The following is a description of a gene set: Any process that activates or increases the frequency, rate or extent of cell differentiation. species: Homo sapiens Human Gene Set: GOBP_POSITIVE_REGULATION_OF_CELL_DIFFERENTIATION, and this is the list of marker genes: LCK, TNFSF14, AGTR1, CLDN5, CLCN2, LEF1, FGF20, NPTN, MCUB, HLA-DRB1, KRAS, TCF15, LAMB2, JUNB, MYOG, JAG1, CHODL, KLF10, NRCAM, JUND, CXCL9, SKIL, MIR21, TRPM4, IL6ST, ACTB, CD74, NPPC, XKR8, TACSTD2, ARID1A, LRRC8A, BMPR2, SMAD4, MDK, ACIN1, WWTR1, HES1, SMARCD1, CD34, RANBP3L, DBN1, RHEB, EP300, TLR9, DAB1, CSF2, CSF3, CEBPD, RASGRP1, FADD, CYP27B1, PCID2, FOXN1, EVI2B (ecotropic viral integration site 2B), RARA, TRPV2, CD101, CCN1, PBRM1 (NCBI Gene Id 55292), LGALS3, STAT5A, INS, PLA2G2A, FXR2, NKX2-5, PARP6, ZHX3, ETV2, TGFBR2, ASB4, ANKRD27, GDI1, BMAL1, RAP1A, PARP1, ACVR2A, LRP3, IL13, VSTM2A, TESPA1 (NCBI Gene Id 9840), PCP4, BRINP2 (NCBI Gene Id 57795), ARID2, ACTN3, FRZB, ZAP70, MAMSTR, OLFM2, NIN, MYOD1, GOLGA4, ROBO2, FEZF1, CTNNB1, WNT2, RPS6KA3, BRD1, NR6A1 (nuclear receptor subfamily 6 group A member 1), IL2, NGF, NOCT, RPTOR, EPO, SHH, NRDC, SHTN1, LIMK1, MIR142, NEUROG1, PRMT5, PRMT3, TARBP2, FZD3, BTC, IL21, QKI, DISC1, HLA-DRA, CUL7, NME2, SERPINE2, CDH4, TGFB1, SMYD1, PCK1, MYOCD (myocardin), CR1 (complement C3b/C4b receptor 1 (Knops blood group)), TFE3, MIR27A, GHR, ISL1, MALT1, PAX8, GDPD2, PNP, SLITRK1, MIR20A, RB1, RAB21, CREBL2 (cAMP responsive element binding protein like 2), IL10, CAPRIN2, RUNX3, ITGB1, EEIG1, FGF18, STAU2, VWC2L, ADCY10, MAP1B, PRKCH, CMKLR1, MIR17 (NCBI Gene Id 406952), ACTL6B, SOX6, IL5, PAX2, MPL, SLC7A5, HOXA5, GATA2, DSCAM, SMARCD2, TP63, IL15, BRINP1, IPO7, SDCBP, MACROH2A2, ADAM7, DLX2, ADM, ALX1, NKAP, ZNF219, F11R, TBX1, SPAG9, TCF7L2, NFKBIZ, GLI2, MIR150 (NCBI Gene Id 406942), DKK1, BCL6, SOCS2, PIAS1, MIR204 (NCBI Gene Id 406987), PTCH2, GATA3, PWP1, CYLD, DDR2, PPP1R13L, BMP6, BCL2, SRF, HOXD3, ZFP36L1, SIRT6, SLIT2, SOX13, PPP1CC, MICOS10-NBL1, SOX10, KITLG, CDKL3, MIR145, ROBO1, CCN3, PTK2, GFAP, INHBA, ADNP, LPAR3, CSRP3, EGR2 (NCBI Gene Id 1959), SP7, LMOD3, LTF, APOB, BOC, TNF, TCF3, BMP10, TWIST1, EDN1, LIN28A, ITPKA, TRIB1, SMARCC1, ETV4, ABCB10, MUSTN1, RHOA, FOXJ1, SOX17, PDPN, ZNF703, RIN2, PHF10, SIX1, MIR221, MESP1, ZEB2, SOX9, ASCL1, MIR99B (microRNA 99b), FN1, CDON, RNF112, SOCS5, MIR137, ZNF335, TP73, RUFY3, AMIGO1, NRP1, ZFHX3, ADAMTS20, MDM2, SPRR5, SH3GL3, FAM210B, HAX1, ADD1, NTRK2, HAP1, KHDC3L, WDR62, GDF5, MAP2K1, HNRNPU, SYK, MIR210, DNAI3, SPDEF, KDR, MACROH2A1, CAMK1, DDRGK1, DMRTA2, GDF10, SHOC2, MMD2 (NCBI Gene Id 221938), CASP8, PTPRZ1, MAN2A1, NUMBL, RARRES2 (retinoic acid receptor responder 2), HIF1A, SOCS1, CCL19, PRKDC, TWF2, FOXG1, PRKD1, TRAK1, MIR181A2, IL4, AURKA, STK4, MSR1, ANAPC2, AKIRIN1, IL20 (interleukin 20), HMGB2, CARM1, PLXNB1, ATRAID, IL1RL2, PPP3CA, PLA2G10, ADAMTS9, NBL1, MIR342, FXR1, METRNL, LHX1, IL1RAPL1, SPI1, OPA1, FMR1, TGIF1, ASXL2, TAL1, KAT5, PITHD1, EEF2K (eukaryotic elongation factor 2 kinase), AGER, RGS14, VNN1, ENG, IGFBP3, VSIR, WNT5B, CRB2, DCT, MIR29B1, RCOR1, LYN, CLCF1, ASPM, CD4, CALCA, WNT3A, SHB, CEBPA, GPR68, IL18, GRM5, ADA, PRKCZ, HSF1 (NCBI Gene Id 642255), OTP, TMEM64, MAPK9, PRKCI, GPRC5B, ADIRF, AP3D1, ADAM8, L1CAM, CD83, SMARCA2, MAP3K5, HDAC2 (histone deacetylase 2), S1PR2, IFNG, PTPRD, ZNF385A, SIRT2, CD80, PTGS2, RAPGEF2, PAFAH1B1, PAX6, MIR548D1, RUNX2, GDF2 (NCBI Gene Id 51423), POU4F1 (NCBI Gene Id 730659), GLIPR2, CX3CR1, IL12B, ADIG, GCNT2, BTK (Bruton tyrosine kinase), RUNX1, AR, MYB, DMD, PF4, S100B, TMPRSS12, MAPT, ACVR1, BAMBI, CTHRC1, MAP3K13, THPO, RND2, ZBED2, TYROBP, IL2RG, CCN6, AXL, HLA-G, TENT5A, OPRM1, WNT4 (NCBI Gene Id 54361), TRPC5, PDE3A, AMBRA1, GDF3, MAML1, FAXDC2, TRIM32, NID1, GATA5, CSF1, CCDC3, ARMCX5-GPRASP2, PTN, PIM1, MIR206, NEDD9 (NCBI Gene Id 4739), PLA2G5, FOXA1 (NCBI Gene Id 3169), TERT, PLAG1, PPARD, AHI1, TTBK1, FEZF2, MYF5, PKP1, SYAP1, GPC1, MIR146A, PPARGC1B, SIN3A, HSPA1B, ISG15, SFRP1, CD27, ZBTB7C, TNFRSF1B, FNDC5, BRAF, LIF, ZFP36, PARP2, ZNHIT1, HMG20B, CLEC7A, IST1, MIR486-1, FZD1, TBX20, SOD2, MIR18A, PLA2G3 (NCBI Gene Id 50487), STK25, ZNF268, SEMA7A, SUCO, SERPINE1, WNT7B, CCR1, OVOL2, EFNA5, RFX3, PPARG, BNIP2, RRAS, FOXC1, MIR140, TNFRSF12A, TPH1, ARRB2, HSPA1A, MTURN, LILRB4, SOX2, ITPKB, SAV1, GSK3B, OBSL1, RAB7B, HDAC1, BLOC1S6, CTNNBIP1, BIN1, NCOA3, TENM4, MIR222, NEUROD2, CUX1, HOXB4, EPHA4, ALOX15B, BMP4, ANKRD54, ELL3, NCKAP1L, NAPEPLD, LRP2, PTPRC, RPS6KA1 (ribosomal protein S6 kinase A1), INSM1 (INSM transcriptional repressor 1), RHOH, NEUROG3, MIR200C, MAP2K2, SEMA5A, SHOX2, IRX3, NEUROD1, IL1B, TRAF6, MME, VHL, PHOX2B (NCBI Gene Id 8929), IL2RA, EMP2, LTBP3, MIR511, IL12RB1, MAPK14, VEZF1, GATA1, GSX2, TAOK3, ZBTB16, OLFM1, ZBTB7B, ADRA2B, DICER1, PTCH1, VEGFC, FERMT2, NCOA1, OCSTAMP, SPINT1 (serine peptidase inhibitor, Kunitz type 1), PROM1, GPER1, PLXNB2, MIR499A, MAG, GDF7, IL4I1, AAMDC, ADIPOQ, GAS6, POU4F2, NUMB, EGR3, MIR125B1, CDKL5, GDF6, NEURL1, KCTD11, SNW1, CXCL12, CLIC1, NF2, FOS, TRIM16, KLHL25, EFNB2 (ephrin B2), VDR, ATP11A (NCBI Gene Id 84170), NR5A2, HGF, STAT5B, CPNE1, PLCB1, IHH, ZMIZ1, INPP5D, SMURF1, KAT2A, HIF1AN, CD24, TSPO, IL17A, KDM1A, MIR133A1, PIEZO1 (piezo type mechanosensitive ion channel component 1 (Er blood group)), TIAM1, HSP90AB1, ETV5, FBXO5, DUSP10, BTG1, RBM24, DKKL1, TMEM100, RELN, MEGF8, SCUBE3, TGFB1I1, TMEM119, ZBTB1, XBP1, FBXW8, SFN, FOXO3, KLF5, GPR65, BDNF, UPF3B, TGIF2, RAG1, PRKG2, IMPACT, FZD4, KAT7, NRG1, NTRK3, SS18L1, MIR519D, IL23A, CBFB, NEFL, SOX12 (NCBI Gene Id 6666), ZNF488, TCF12, NEUROD4 (neuronal differentiation 4), PROX1, IL36B, LRP8, SEMA4D, UFL1, BTN2A2, SERPINB3, MYRF, CD46, BRD7, GJA1, ISLR2, CTH, LTA, DRD2, SERPINF2, SLC6A6, KIT, SLC9B2, MIR199A1, ANXA1, SOCS3, MIR133B (NCBI Gene Id 442890), GDPD5, SCIN, NAP1L1, FBN2 (fibrillin 2), IL7R, TNFSF11, SETD3, ATOH8, SMAP1, MAPK11, IFITM1, TRPC6, IGF1, HOXA11, EDN3, DCSTAMP, SULT2B1 (NCBI Gene Id 6820), BMPR1A, CDH5, TGM2, NKX6-1, TNFRSF11A, XRCC2, MACF1, POR, EZH2, TESC, SASH3, IL6R, PA2G4, FGF2, BRD4, DAG1, WIF1, WNT10B, ACVRL1, ZBTB46, KAT8, ZNF365, SRRT, EPHB2, LRP5, CDX2, MSX2, NUDT21, RIPOR2, ID2, ID4, CRABP2, TIAM2, VEGFA, DPF3, STAT1, NKX2-2, CCL8, CREB1, TCF4, ARID1B, MIR199B, CDS1, NLRP3, CEBPB, MIR208A, NR2E1, CCN2, ACTL6A, EFEMP2, BEND6, RBM4, RIPK1, HTR2A, RAMP2, SMAD2, AXIN2, BLOC1S5, ATOH1, HOPX, CAV3, SNAI1, PROC, FOXP3, BAIAP2, ZC4H2, RIPK2, SMARCB1, SMAD5, PLXNB3 (NCBI Gene Id 5365), LAMA2, MEDAG, MIR3648-1, IL34, MIR20B, LIG4, DLX1, SOX11, NFKB1, SFRP4, RHEX, LPL, MAP6, FGFR1, BMP2, ACVR2B, SART1, LAMA1, RASSF10, GLI3, MYLK3, SNAI2, REST, SMARCA4, MMP14 (NCBI Gene Id 4323), ACVR1B, MIR19B1, TBC1D24, PLAAT4, RREB1, SIRT1, IL23R, BRD2, ATXN1, ARHGEF2, NOTCH1, BMPR1B, DUOXA1, PPP2R3C, DPF1, SMARCD3, MIR181B1, WDFY2, SOX8, BMP7, NKX6-2, CUX2, PRKCA, FGF8, PRMT1, GLUL, MIR185, NTN1 (NCBI Gene Id 9423), SLC30A1, ABCB1, MIR19A, MIR34A, PKDCC, ECT2, SPEN (NCBI Gene Id 348488), SMAD1, IL6, TBX5, CAMK2B, MECP2, ZC3H12A, TREM2, CX3CL1, ZEB1, LAMC1, HEYL, SOX4, XRCC6, TGFBR1, CXCR4, LMO3 (LIM domain only 3), EIF4G1 (eukaryotic translation initiation factor 4 gamma 1), AGT, ARNT, STK11, TGFB3, PAK1, LGALS1, XRCC5 (X-ray repair cross complementing 5), CYP26B1, NOTCH4, TGFB2, FES, RGCC, NPNT, HDAC6, WNT3, NAP1L2, MIR424, PIK3R6, SMAD7, ADRA2C, CD36, IL15RA (NCBI Gene Id 3601), MIR22, ETS1, SOX5, CEACAM1, HMGB1, SERPINF1, TNFSF4, E2F1, GDNF, DHX36, MYF6, HTR2C, NELL1, LOXL2, FFAR4, SMO, YAP1, PLXNC1, MEF2C, BCL9L, AKAP6, MTCH2, MIR106A, BAD, STAT3, SMARCE1, LAMB1, MMD, LILRB2, SULT1E1, NFKBID, COL1A1, BNC1, CCN5, APP, IL4R, MED1, VWC2, ZNF16, MAPK12, CD86, LRG1, SMARCC2, IL7, NUMA1, MTOR, FAM20C, HLX, SMAD3, JAK2, HCLS1, ILK, NOTCH2, SHANK3, AKT1, PLXND1, LGALS9, TNFSF9, STK3, BCL11A, MIR1-1, BRINP3, ZFYVE27, METRN, SFRP2, TOX (NCBI Gene Id 9760), KDF1, TM4SF19, TNXB, OLIG2, DAB2, RELA, GPRASP3, CYB5D2, AP3B1, CAPRIN1, CCN4